Given this list of marker genes Itfg2, Ighd, Mlh1, Wnt3a, Mfng (NCBI Gene Id 17305), Bmi1, Tlr4, Cdkn1a, BC037156, Bad, Shld3, Ccr6, Gm13271, Clcf1, Ifnab, Pkn1, Ifna1, Tirap, Shld1, Hmces, Bax, Msh2, Dcaf1, Adgrg3, Lyn, Il7r, Slc15a4, Aplf, Cxcr5, Cr2, Exo1, Slc39a7, Trp53, Ifna7, Shld2, Ndfip1, Hhex, 6030468B19Rik, Il9r, Ahr, Tnfrsf4, Ifne, Ptprc (protein tyrosine phosphatase receptor type C), Ms4a1, Muc19, Ighm, Il3, Atp11c, Exosc6, Igbp1b, Tnfrsf13b, Tyrobp (NCBI Gene Id 22177), Cd22, Stat5a, Tcf3, Dpp4, Lrrc8a, Ercc1, Aicda, Sfrp1, Foxp1, Fcgr2b, Cd38 (NCBI Gene Id 12494), Kit, Fcrl1, Il4i1, Il2rg, Plcg2, Foxp3, Cd24a, Cmtm7, Il27ra, Btla, Tnfaip3, Ifna11 (NCBI Gene Id 230403), Il2, Ddrgk1, Pik3cd, Notch2, Ifna5, Bcl2, Nckap1l, Slamf8, Trp53bp1, Vpreb1b, Gm13272, Cd79b, C3, Ada, Batf, Kmt5b, Ankle1, Mir181b-2, Mad2l2, Cfb, Plcl2, Phf14, Cyld, Mir92-1, Ighe, Mmp14, Ntrk1, Slc39a10, Cd74, Ifng, Gon4l, Ezh2, Ifna14, Prkcb, Shb, Xbp1, Icosl, Igbp1, Spib, Traf3ip2 (NCBI Gene Id 103213), Il21, Ung, Fzd9, Pagr1a, Syvn1, Prkdc, Parp3, Aqp8, Bcl11a, Nkx2-3, Ep300, Ifna16, Ephb2, Cd320, Lgals1, Chrna7 (cholinergic receptor, nicotinic, alpha polypeptide 7), Irs2, Tgfb1, Dock11, Zbtb7a, Il5, Slc25a5, Rasgrp1, Cd19 (CD19 antigen), Lgals8, Gm13283, Themis2, Zfp36l1, Irf8, Ptprj, Mir19a (microRNA 19a), Phb2, Bak1, Lef1, Vpreb1a, Cdkn2a, Onecut1, Tnip2, Irf2bp2, Bcl3, Jak3, Lyl1, Ifnb1, Kmt5c, Dll1, Card11, Ifna6, Cd180, Cd79a, Cd40lg, Flt3l, Xrcc4, Tcirg1, Tbc1d10c, Ptpn2 (NCBI Gene Id 19255), Sash3, Stat5b, Pnp, Tshr, Ctla4, Rc3h1, Ctps1, Ifna4, Prlr, Pms2, Cdh17, Il10, Mzb1, Cd86 (NCBI Gene Id 677252), Swap70, Sp3, Bank1, Igkc, Lfng, Sh3kbp1, Atad5, Tnfsf4, Lax1, Ifnk, Supt6, Polm, Lat2, Igkj5, Cd27, Btk, Gpr183 (NCBI Gene Id 321019), Txlna, Hdac7, Pcyt1a, Rnf8 (NCBI Gene Id 70689), Syk, Peli1, Spi1, Cebpg, Il7, Adam17, Tfrc, Gps2, Ptk2b, Chrna4, Cd81, Zfp36l2, Ticam1, Hdac5, Nfkbiz, Cd70, Zbtb1, Mir19b-1, Tlr9, Bcl6, Pten, Pfdn1, Ifnz, Pou2f2, Rnf168, Ifna2, Mir18, Gm11690, Tnfrsf21, Hdac9 (histone deacetylase 9), Enpp1 (NCBI Gene Id 97628), Tnfsf13, Siglecg, Fas, Nfatc2, Foxj1, Rabl3, Pou1f1, Gm13276, Atm, Rbpj (recombination signal binding protein for immunoglobulin kappa J region), Skap2, Mir17, Mir181b-1, Tnfsf13b, Dnajb9, Nbn, Nfatc1, Inpp5d, Mef2c, Cd300a, Stat6, Nhej1 (NCBI Gene Id 75570), Ptpn6, Ppp2r3c, Cd40 (NCBI Gene Id 98930), Ifna9, Blnk, Gapt, Exosc3, Rif1, Myb, Ifna13, Abl1, Il9, Gm13275, Mif, Itm2a, Pik3r1, Gimap1, Vav3, St3gal1, Sanbr, Samsn1, Bst1, Nfam1, Fosl2, Gm13277, Dock10, Hmgb3 (high mobility group box 3), Prkcd, Tpd52 (NCBI Gene Id 99538), Top2b (topoisomerase (DNA) II beta), Tsc2, Nod2, Flt3, Rag2, Akirin2, Fnip1, Pou2af1, Ighg1, Laptm5, Pcid2, Chrnb2, Il6, Id2 (NCBI Gene Id 97802), Ikzf1, Hspd1, Hmga1, Ifna15, Tnfrsf13c, Casp3, Yy1, Ikzf3, Msh6, Mir150, Paxip1, Tbx21, Lilrb4a, Ifna12, Il13, Nsd2, Il4, Mir20a, Malt1, Phb1, Rag1, Dclre1c, Lig4, Pawr, Cd28, here is a description of the gene set: species: Mus musculus The change in morphology and behavior of a mature or immature B cell resulting from exposure to a mitogen, cytokine, chemokine, cellular ligand, or an antigen for which it is specific. Mouse Gene Set: GOBP_B_CELL_ACTIVATION